The following is a description of a gene set: studied in species Homo sapiens Human Gene Set: GOMF_EXTRACELLULAR_MATRIX_STRUCTURAL_CONSTITUENT_CONFERRING_COMPRESSION_RESISTANCE A constituent of the extracellular matrix that enables the matrix to resist compressive forces; often a proteoglycan., and this is the list of marker genes: LUM, ENAM, PRG2, HAPLN1, ACAN, AMELY, PRG3, DCN, FMOD, BGN, STATH, AMBN, HSPG2, OGN, ASPN, VCAN, PODN, CHADL, TUFT1, PRELP, PRG4, AMELX